The following is a description of a gene set: Mouse Gene Set: GOBP_MOTILE_CILIUM_ASSEMBLY The aggregation, arrangement and bonding together of a set of components to form a motile cilium. species: Mus musculus, and this is the list of marker genes: Rsph9, Jhy, Fsip2, Ccdc39, Lrrc46 (leucine rich repeat containing 46), Ccdc146, Yif1b, Cfap54 (NCBI Gene Id 74958), Tpgs1, Rsph6a, Zmynd10, Zmynd12, Atmin, Cfap119, Ccdc40, Spag6, Pla2g3, Misfa, Dnaaf11, Cfap53, Dynll1, Spata6, Ttll5, Neurl1a, Bbs4, Cfap58, Cfap47 (NCBI Gene Id 667736), Ahi1, Enkd1, BC048507, Armc2, Vdac3, Cfap65, Spag16, Bbs2, Cfap157, Spef2, Cfap221, Mns1 (meiosis-specific nuclear structural protein 1), Gk2, Dnhd1, Dnali1, Cfap43, Poc1b, Cfap61, Cfap44, Iqcn, Htt, Dzip1, Ccdc159, Dnaaf1, Mir34b, Foxj1, Mir34c, Cc2d2a, Armc12, Drc7, Ccdc38, Ift57, Tbc1d21, Mks1, Cfap70, Cfap206, Ttc12, Cabcoco1, Ulk4, Mir449b, Mir449a, Ift88, Spag6l, Cep131, Klc3, Mir449c, Intu, Ube2b, Drc1, Dnah1, E2f4, Iqcg, Cenpj, Spag17, Dnaaf3, Cfap57, Ttll1, Mcidas, Kif3a, Noto, Cfap97d1 (CFAP97 domain containing 1), Bbof1, Pdcl2, Akap4, Pfn4, Meig1, Cep128, Ift81, Cfap69